Given this list of marker genes KLF4, RYR1, ABHD17C, AKT1S1, PARD6G, PLXNA1, RFX1, GRINA, PGAP1, GRAP, ADRB2, HVCN1, ANXA4, PMM1, VEGFB, MMP12, SLC25A15, MAG, KLF9, SSH3, ANO6, AMDHD2, GPR132, GDE1, TP53RK, PPP1R14B, LRRC20, DHRS3, MZB1, CD163, CD36, ZYX, ATP6V0D1, PHF1, ASAP1, PPP1R37, DDX19A, MLF2, COTL1, DDHD1, ATXN7L3 (ataxin 7 like 3), SP2, S1PR1, DCTN4, SAMTOR, SLC38A7, ANPEP, TUSC1, TSPAN17, HRAS, MIA3, RNF128, GLTP, FUOM, BST1, SNAPC2, RAVER1, ARF4, CEBPA, F7, ACTR1A, NRBP1, C12orf43, KLF16, CD22, ADPRH, MTF1, ARHGAP1, GASK1B, MFSD5 (NCBI Gene Id 84975), DCSTAMP, GALNS, TUBB2A, HSP90B1, TSPOAP1, SNX9, CAPNS1 (NCBI Gene Id 826), LMO2, C19orf47, DNAJC6, ATP6V0D2, S1PR5, ARHGDIA, SMPD1, SUCLG1, IL12B, RNF31, ALDH2, ATG16L1, NUP42, SYN1, CPEB4, CA5B, CLEC7A, EDEM1, SLC49A4, ALDH1B1, HPS1 (NCBI Gene Id 3257), EVL, FASTK, TMA16, GDF15, DSTN (NCBI Gene Id 11034), BRI3, DDA1, PON2, PLEKHO2 (NCBI Gene Id 80301), SELL, RNF181, TMEM150A, NPC1, CACFD1, CDKN1C, ATXN2, TRIM3, OXCT1 (3-oxoacid CoA-transferase 1), ZFTRAF1, PPIF, F10, RAD52 (NCBI Gene Id 5893), ACBD3, ALDH16A1, OPTN, KMT5C, CHMP1A, PPP1R12B, OS9, PPP1R18, CARNS1, MTSS1, F13A1, CLN5, PROCR, STIM1, ATXN2L (NCBI Gene Id 11273), AP3S1, CHST7, RARRES2, STMP1, ZBTB21, WNT5B, RNPEP, LPIN1, GUCD1, FCRL1, FRY, VIM, PTGIR, CTSZ, TIMD4, CASS4, SLC7A11, GCLM, LRG1, VSIG8, STX6, STAB2, TTYH2, DCTN2, WSB2, ASRGL1, IFT70B, PGRMC2, SH3BP1, MFSD12, SOCS7, ABHD16A, CD79A, GUK1, MAVS, GK5, MAPKAPK2, CCDC88A, ATP6V0B, COL15A1, FLOT2, ST8SIA6 (NCBI Gene Id 338596), SLC7A4, CEBPB, RALGDS, TOMM40, GSTM1, BCAR3, MYO5A, MEOX1, MERTK, BACH2, IGHG1, COMTD1, PLA2G7, ITPK1, TMCC1, RGL1 (ral guanine nucleotide dissociation stimulator like 1, NCBI Gene Id 23179), BAK1, SH3BGRL, COLGALT1, SAMD8, TRPC4AP, RIN3 (NCBI Gene Id 79952), PLD3, here is a description of the gene set: from publication Yamagata T, Benoist C, Mathis D (PMID 16623764) studied in species Homo sapiens Three innate (B1-B, NKT, CD8aaT cells) and adaptive (B2-B, CD4T, CD8abT cells) cell-types were sorted by FACS. Three biological replicates for NKT, CD4T, CD8aaT, CD8abT cells and two biological replicates for B1 and B2 cells were generated and the expression profiles were determined using Affymetrix Mu74Av2 chip. Comparisons between the sample groups allow the identification of genes differentially expressed between the innate and adaptive cell-types. Human Gene Set: GSE3039_CD4_TCELL_VS_ALPHAALPHA_CD8_TCELL_UP Genes up-regulated in T cells: CD4 versus CD8A.